Given this list of marker genes Kat2b, Rnf11, Ddt, Hp, Samm50, Ltc4s, Sox15, Plin4, Etfdh, Cyrib, Pdap1, Apmap, Pdhb, Decr1, Lum, Phb2, Uqcrc1, Prxl2a, Cbr1, Impdh1, Mrpl51, Col15a1, Grhpr, Tkt, Cidec, Acaa1a, Apoe, Adig, Cib2 (NCBI Gene Id 80498), Bbln, Psen2, Chpt1, Gdf5, Sdhb, Lonp2, Slc25a1 (NCBI Gene Id 76777), Uqcr10, Orm2, Sdhc, Fxn, Cat, Acaa2, Nes, Gbe1 (1,4-alpha-glucan branching enzyme 1), Poln, Pla2g6, Cs, 2310061I04Rik, Uqcrb, Parm1, Pgm2, Abca1, Cd1d1, Hibadh, Rarres2, Bnip3, Scp2, Isoc1, Aoc3, Pex19, Sdha, Acad9, Nabp1, Dgat1, Hibch, Orm1, Dhcr7, Fah, Ndufb7, 4931406C07Rik, Cdip1, Sgcd, Bckdhb, Noct, Hsd17b4, Dld (dihydrolipoamide dehydrogenase), Sowahc, Scarb1, Wfdc12, Suclg1, Cox7a2, Trp53inp2, Reep5, Mc2r, S100a8, Cyb5a, Rbpms, Ogdh, Ndufc1 (NCBI Gene Id 66377), Pnpla2, Ndufa9, Retn, Pon2, Dhrs7b, Lpl, Dlat, Ndufb9, Cdkn2c, Lias, Agpat3, Tank, C1qtnf12, Ccng2, Alas1, Cmbl, Acadl, Ehd1, Pxmp2, Ndufs3, Me1, Pla2g12a, Gsr, Fmc1, Mgst1, Cfd, Coq5, Adipoq, Phtf2, Unc119, Acads, Reep6, Mgll, Aqp7, Thrsp, Car2, Arxes2, Aldh1a7 (aldehyde dehydrogenase family 1, subfamily A7), Hadh, Itga6, Ndufb2, Arl4a, Cox7b, Rab3d, Camp, Qki, Mrap, S100a1, Uck1, Ndufb6, Cavin2, Car3, Tab3, Ndufb5, Cyb5b, Tspan12, Ubd, Fasn, Adissp, Nr1h3, Mpdu1, Uqcrc2, Sfxn1, Uqcrq, Dlst, Tst, Alad, Ndufb8, Qdpr, Atp5f1d, Apoc1, Atp5po, Abcd2, Acyp2, Ndufa5, Dbt, Dnajc15, Gpd1, Ldhb, Chchd3 (coiled-coil-helix-coiled-coil-helix domain containing 3), Slc19a1, Nnmt, Tufm, Lcn2, G0s2, Mccc1, Cd151, Gcsh, Hsd11b1 (NCBI Gene Id 215261), Adcy6, Ndufs1, Cox5b, Hsd17b12, Slc2a4, Bcat2, Gm15834, Ndufb3, Map4k4, Hipk2, Slc25a10, Retsat, Isca1, Ppp2r5a, C9orf72, here is a description of the gene set: from publication Burton GR, Nagarajan R, Peterson CA, McGehee RE Jr (PMID 15033539) Strongly up-regulated at 96 h during differentiation of 3T3-L1 cells (fibroblast) into adipocytes. During cellular differentiation and development, it is recognized that many complex molecular mechanisms as well as precise patterns of differentially expressed genes occur in directing precursor cells toward a given lineage. Using microarray-based technology, we examined gene expression across the course of 3T3-L1 adipocyte differentiation. Total cellular RNA was isolated at times 0, 2, 8, 16, 24, 48, and 96 h following treatment with either standard hormonal inducers of differentiation; insulin, dexamethasone, isobutylmethylxanthine (IDX), or IDX plus trichostatin A (TsA), a histone deacetylase inhibitor and potent adipogenic inhibitor. cRNA was synthesized from cellular RNA and hybridized to high density Affymetrix MG_U74Av2 microarray gene chips containing 12,488 cDNA/Expressed Sequence Tags (ESTs) probe sets. From the IDX-only treated cells, all probe sets that were either unchanged or differentially expressed less than 2-fold throughout differentiation with respect to time 0 preadipocytes were excluded from further analyses. This selection resulted in a net of 1686 transcripts, 859 were increased in expression, and 827 were decreased in expression at least 2-fold across differentiation. To focus in on genes that were more specific to differentiation, the same analysis was performed on IDX plus TsA-treated non-differentiating cells and all probe sets from the IDX-only group that exhibited similar expression profiles in the non-differentiating TsA-treated group were excluded leaving a total of 1016 transcripts that were regulated only under differentiating conditions. Six hundred and thirty-six of these transcripts were elevated at least 2-fold and 380 exhibited a decrease in expression relative to time 0 preadipocytes. This group of genes was further analyzed using hierarchical clustering and self-organizing maps and resulted in the identification of numerous genes not previously known to be regulated during adipocyte differentiation. Many of these genes may well represent novel adipogenic mediators and markers of adipogenesis. species: Mus musculus Mouse Gene Set: BURTON_ADIPOGENESIS_6